Given this list of marker genes TBX5, HIPK1, CCN2, RUNX2, WWTR1, NKX2-5, TEAD2, GATA4, TEAD1, YAP1, TEAD3, HIPK2, TEAD4, KAT2B, NPPA, here is a description of the gene set: studied in species Homo sapiens Reactome Pathway: YAP1- and WWTR1 (TAZ)-stimulated gene expression part of: Generic Transcription Pathway YAP1 and WWTR1 (TAZ) are transcriptional co-activators, both homologues of the Drosophila Yorkie protein. They both interact with members of the TEAD family of transcription factors, and WWTR1 interacts as well with TBX5 and RUNX2, to promote gene expression. Their transcriptional targets include genes critical to regulation of cell proliferation and apoptosis. Their subcellular location is regulated by the Hippo signaling cascade: phosphorylation mediated by this cascade leads to the cytosolic sequestration of both proteins.